The following is a description of a gene set: from publication Hebert JD, Myers SA, Naba A, Abbruzzese G, Lamar JM, Carr SA, Hynes RO (PMID 32019869) Tumor cell-derived matrisome proteins found in significantly higher abundance in TNBC brain, bone, liver and lung metastatases compared to normal samples. Human Gene Set: HEBERT_MATRISOME_TNBC_BONE_BRAIN_LUNG_LIVER_METASTASTASES_TUMOR_CELL_DERIVED species: Homo sapiens We have previously developed methods for enriching tissue samples for their ECM protein content by taking advantage of the relative insolubility of the ECM, and we have used these techniques in conjunction with mass spectrometry-based proteomics to profile the matrisome, the complete collection of both core ECM and ECM-associated proteins, in several different cancers. Here we define and compare the ECM components of metastatic niches and how they differ among the specific secondary sites common in TNBC. For this purpose, we use as a model the MDA-MB-231 human TNBC cell line, originally derived from a patient pleural effusion (24), which is capable of metastasizing to the brain, lungs, liver and bone marrow in mouse xenografts. We identify which ECM proteins are commonly elevated at multiple different metastatic sites, and which are preferentially elevated in particular sites. We investigate how these specific ECM proteins, as well as the tumor matrix overall, are differentially produced by the tumor and stromal cells; in this paper, we use stromal to include all cells in the tumor that are not tumor cells. These comparisons did not simply identify the most elevated proteins in each tissue, but rather the proteins most significantly different in abundance in one tissue relative to all others. Separate analyses were conducted for tumor-cell-derived (human) and stroma-derived (mouse) proteins. In this study, we performed an unbiased, quantitative mass spectrometric survey of ECM proteins present in MDA-MB-231 breast cancer xenograft metastases to the brain, lungs, liver and bone marrow. This gene set lists the tumor-cell secreted matrisome proteins found in significantly higher abundance in TNBC brain, bone, liver and lung metastatases compared to normal samples., and this is the list of marker genes: ANXA2, ANXA1, S100A4, SERPINB1, COL4A1, CTSD, HSPG2 (NCBI Gene Id 7796)